The following is a description of a gene set: Abnormal sweat homeostasis Human Gene Set: HP_ABNORMAL_SWEAT_HOMEOSTASIS studied in species Homo sapiens An abnormality of the composition of sweat or the levels of its components., and this is the list of marker genes: FCGR2A, NEK10, GSTM3, MIF, SLC11A1, GUCY2C, EDNRA, SCNN1A, CFTR, FUCA1, KCNN4 (NCBI Gene Id 3783), CLCA4, DCTN4, SLC9A3, SCNN1B, CEACAM3, CCNO, CA12, TGFB1, GCLC, AGR2, HMOX1, SLC6A14 (NCBI Gene Id 282807), CEACAM6, PNLIP, STX1A, SERPINA1, HFE, SLC26A9